The following is a description of a gene set: Human Gene Set: GOCC_EARLY_ENDOSOME_LUMEN The volume enclosed by the membrane of an early endosome. studied in species Homo sapiens, and this is the list of marker genes: RAB32, PDLIM4, RAB38, LNPEP, B2M